Given this list of marker genes Fgf5, Fgf17, Cilp, Fgf6, Shc1, Fgf4, Fgf20, Irs2, Pik3cb, Igf2, Fgfr1, Fgf15, Kl, Frs2, Flt3l, Irs4, Fgf16, Tlr9, Pdpk1, Pik3c3, Klb, Grb2, Fgf2, Pik3r2, Fgf10, Fgf8, Fgf23, Fgf7, Them4 (thioesterase superfamily member 4), Fgf22, Fgf1, Gab1, Irs1 (NCBI Gene Id 16367), here is a description of the gene set: Reactome Pathway: Signaling by Type 1 Insulin-like Growth Factor 1 Receptor (IGF1R) electronically inferred by orthology from the curated human pathway part of: Signaling by Receptor Tyrosine Kinases This event has been computationally inferred from an event that has been demonstrated in another species.<p>The inference is based on the homology mapping from PANTHER. Briefly, reactions for which all involved PhysicalEntities (in input, output and catalyst) have a mapped orthologue/paralogue (for complexes at least 75% of components must have a mapping) are inferred to the other species. studied in species Mus musculus